Given this list of marker genes PLD3, POU3F2, CLEC4A, GJA5, CD68, SND1, SPP1, TCEAL9, SCD, APOC1, CCL23, COTL1, LILRA4, LRP5 (NCBI Gene Id 8058), CTSZ, CTSD, PSMA4 (NCBI Gene Id 5685), SNCB, CFL1, F7, WFDC21P, PIGT, IQGAP1, ATG7, CSF2RB, RAP2B, LY75, AXIN2, CAVIN1, MYO7A, AGAP3, CTSS, CCL3, RASGRP2, ADAM15, USF1, LRG1, IFITM10 (interferon induced transmembrane protein 10), SAT1, PDIA4, CSTB, LPL, LYZ, PLET1, CCN3, BASP1, TBL3, SMAP2, BCL2L11, AGPAT1, ACP5, LCN2, CTSK (cathepsin K), SH3RF1, TLE5, ITGAX, MPEG1, PTGDR2, SOCS3, SYK, SEMA6A, SP4, AGO2, here is a description of the gene set: Human Gene Set: STEARMAN_LUNG_CANCER_EARLY_VS_LATE_DN One area of intensive investigation is to understand complex cellular and signaling interactions in the tumor microenvironment. Using a novel, although straightforward, microarray approach, we defined a gene expression signature from the lung tumor microenvironment in the murine A/J-urethane model of human lung adenocarcinoma. The tumor microenvironment is reflected by the composition of the cell types present and alterations in mRNA levels, resulting in a Field Effect around the tumor. The genes composing the Field Effect expression signature include proteases and their inhibitors, inflammation markers, and immune signaling molecules. By several criteria, the Field Effect expression signature can be attributed to the macrophage lineage, suggesting a qualitative change in the expression pattern of tumor-associated macrophages (TAM) observed in lung tumors. The protein expression levels for a number of Field Effect genes were verified by Western blot analysis of lung homogenates, and for their expression in macrophages and parenchymal cells outside of the tumors by immunohistochemistry. In addition, the Field Effect expression signature was used to classify bronchoalveolar lavage (BAL) cells from tumor-bearing or age-matched control mice. Using a variety of statistical measures, the Field Effect expression signature correctly classified the BAL cells >94% of the time. Finally, the protein levels for several Field Effect genes were higher in cell-free BAL fluid, indicating they may be secreted by the TAMs. This work suggests that TAMs generate a unique gene expression signature within the tumor microenvironment, and this signature could potentially be used for identifying lung cancer from BAL cells and/or fluid. Down-regulated genes classifying non-tumor lung tissues by age after incution of lung cancer by urethane injection: early (24-26 weeks) vs late (46 weeks). from publication Stearman RS, Dwyer-Nield L, Grady MC, Malkinson AM, Geraci MW (PMID 18172294) species: Mus musculus